Given this list of marker genes GJB1, PMP22, TUBB4A, MFN2 (mitofusin 2), ATP7B, CLN5, PMP2, TSHR, PEX16, NEFL, STUB1, MYBPC1, SMN1, RNU12, TMEM63A, PLP1, IFRD1 (interferon related developmental regulator 1), LMNB1, AARS2, SNRPN, SMN2, TOR1A, SAMD12, CEP104, VPS13A, CTNND2, SPTBN1, CACNA1G, HSPD1, KCNN2, TFG, SH3TC2, ANO3, KIF1C, KARS1, CIZ1, UBE3A, MARCHF6, PGAP1, EIF2AK2, DRD3, CARS2, HIBCH (NCBI Gene Id 26275), ITPR1, ADRA2B, SLC6A17, FGF14, LAMA1 (NCBI Gene Id 3907), POLR1A, RAB3GAP2, ALS2, PEX6, GBA2, MARS1, NOTCH2NLC, GCK (NCBI Gene Id 2645), TRIM8, VRK1, ZFYVE26, FUS, YEATS2, PIGA, TTPA, DDC, ABCB6, MORC2, NGF, TSPOAP1, TENM4 (teneurin transmembrane protein 4), AARS1, MPZ, PDK3, SLC12A6, DNMT1, NOP56, ZFR, GJC2, NPTX1, CAMTA1, POLG, COL6A3, TAF1, PI4KA, TRAPPC6B, UCHL1, ERLIN2, AFG3L2, SETX, SPTLC1, CDC42BPB, PLA2G6, PIK3R5, PDGFB, ITPA (inosine triphosphatase), SCP2, NKX6-2, SPG11, PPP2R2B, TBC1D24, SIGMAR1, PHIP, CNTN2 (NCBI Gene Id 6900), GRIA3, here is a description of the gene set: Human Gene Set: HP_TREMOR_BY_ANATOMICAL_SITE species: Homo sapiens Tremor classified by the affected body part. Tremor by anatomical site